The following is a description of a gene set: Abnormal hemoglobin concentration Any deviation from the normal concentration of hemoglobin in the blood. studied in species Homo sapiens Human Gene Set: HP_ABNORMAL_HEMOGLOBIN_CONCENTRATION, and this is the list of marker genes: AMN, MADD, KLF1, KCNN4, EPOR, HBB, BPGM, EPAS1, PGK1, SH2B3, VHL, HBA2, CUBN, PKLR, JAK2, HBA1, SLC4A1, EGLN1, EPO, PIEZO1